Given this list of marker genes STIM2, CACNA1I, LPGAT1, ENTPD2, KDELR3, CDK18, GUCA1B, SLC6A17, COPG1, FILIP1L, PPT2, INAVA, RDX, DSG3, RNLS, MSS51, NAPA, SHISAL1 (NCBI Gene Id 85352), CASTOR2, PPP2R2D, NFASC, ELOA, SHISA7, WNT7B, MPZ, PVALB, MECP2, ARHGEF10, NAPG, NCAN, ARL5B (ADP ribosylation factor like GTPase 5B), ACTB, RFX3, RNF125, NABP1, CNTNAP1, NFIX, STC1, here is a description of the gene set: studied in species Homo sapiens Genes predicted to be targets of miRBase v22 microRNA hsa-miR-5010-5p in miRDB v6.0 with MirTarget v4 prediction scores > 80 (high confidence targets). Human Gene Set: MIR5010_5P from publication Chen Y, Wang X (PMID 31504780)